The following is a description of a gene set: An abnormally low level of uric acid in the blood. Hypouricemia species: Homo sapiens Human Gene Set: HP_HYPOURICEMIA, and this is the list of marker genes: PRPS1, GATM (NCBI Gene Id 65211), SLC2A2, MOCS2, SLC22A12, NDUFAF6, GPHN, SLC34A1, SLC2A9, ATP7B, MOCOS, MOCS1, CTNS, XDH, PNP, HNF4A, EHHADH